The following is a description of a gene set: As one of the most successful cancer therapeutic targets, estrogen receptor-alpha (ER/ESR1) has been extensively studied over the past few decades. Sequencing technological advances have enabled genome-wide analysis of ER action. However, comparison of individual studies is limited by different experimental designs, and few meta-analyses are available. Here, by ingesting large amount of E2-related transcriptomic data sets in breast cancer cell lines, we identified gene expression changes across 66 RNA-seq and 80 microarray experiments based upon the E2-induced fold change in gene expression. By examining the plasticity of the directionality of estrogen response, we found the correlation of upregulation and downregulation of all genes in the merged data collection revealed a strong nonlinear negative association, showing that most genes exhibited a single monodirectional regulation by estradiol. Unexpectedly, we also identified a subset of bidirectionally regulated genes (n = 101) that are present in the top 10% of both upregulated and downregulated targets and in at least 10% of comparisons. Their divergent regulation was not associated with specific experimental conditions such as E2 treatment duration or cell line context studied in species Homo sapiens from publication Li Z, Li T, Yates ME, Wu Y, Ferber A, Chen L, Brown DD, Carroll JS, Sikora MJ, Tseng GC, Oesterreich S, Lee AV (PMID 37272757) Human Gene Set: LI_ESTROGENE_BIDIRECTIONAL_E2_RESPONSE Bidirectional estrogen regulated genes in breast cancer cell lines merged from 146 NGS datasets-based comparisons (present in the top 10% of both upregulated and downregulated targets in at least 10% of comparisons)., and this is the list of marker genes: PRKCD, GPER1, DUSP5, EPHA2, CYP1A1 (cytochrome P450 family 1 subfamily A member 1), HK2, ARMCX7P, EGR1, TMEM158, GDF1, SECTM1, FUT1, STARD4, ADGRV1, SEMA3E, EIF3CL, SERPINI1, NFAT5, IFIT2, PROS1, RAI2, LSM12P1, GRB14, ASPM, TMSB4XP6, DHRS3, RASSF2, STX11, GPAT3, IFIT1, SYNGR3, GDF15, PTGER2, BDKRB2, ISG15, ETS2, KRT23, FOSL1, IGFBP5, VASN, ZC3H12C, KCNC1, NPR3, NPIPB6, ENOX1, RHOBTB1, MUC1, MSX2, PCP4, SLC29A3, FAT4, TRANK1, RMND1, MAP3K14, MAOA, ABCC2, COQ2 (coenzyme Q2, polyprenyltransferase), MFSD2A, OAS1, RGCC, BRINP2, LMNB1, SLC14A1, ARMT1, ABCG2, CEMIP, PHGDH, SPRY4, DUSP4, FZD7, CLCA2, UNC5A, BHLHE40, EHF, PALM2AKAP2, ALDH1A3, GPRC5A, ABCA12, AGR2, CDC42EP1, LIF, DYNC2H1, RPGR, SRPX, IER3, SLC6A14, PPP1R3C, DLL1, CLSTN2, PDK4, DUSP2, RIPOR3, UBL3, CXCL14, MAFB, MSX1, ADM, NCR3LG1, ENTREP1, DUSP6